Given this list of marker genes RAB3GAP2, BCOR, ZFX, SMS, ASH1L, GAD1, PUF60, here is a description of the gene set: Human Gene Set: HP_ASYMMETRY_OF_THE_EARS Asymmetry of the ears An asymmetriy, i.e., difference in size, shape or position between the left and right ear. species: Homo sapiens